Given this list of marker genes MTHFR, BHMT, MTHFD1, MSRA, ENOPH1 (enolase-phosphatase 1), MTR, SMS, MTRR, ADI1, APIP, MAT1A (methionine adenosyltransferase 1A), BHMT2, GNMT, here is a description of the gene set: species: Homo sapiens The chemical reactions and pathways involving methionine (2-amino-4-(methylthio)butanoic acid), a sulfur-containing, essential amino acid found in peptide linkage in proteins. Human Gene Set: GOBP_METHIONINE_METABOLIC_PROCESS